Given this list of marker genes NPY4R, NPY4R2, NPY1R (NCBI Gene Id 4886), NPY2R, NPY6R, PROKR2, PRLHR, QRFPR, PROKR1, NPY5R, GPR83, here is a description of the gene set: Human Gene Set: GOMF_NEUROPEPTIDE_Y_RECEPTOR_ACTIVITY studied in species Homo sapiens Combining with neuropeptide Y to initiate a change in cell activity.